Given this list of marker genes Lig3, Nuggc, Dach1, Mtnap1, Dynll1, Gmnc, Atrx, Endog, E2f7, Timeless (timeless circadian clock 1), Fbxo5, Zmpste24, Gmnn, Wiz, Ino80, Atg7, Mettl4, Cdc7, Cdk2, Aicda, Kat7, Ilkap, Ciz1, Ssbp1, Ager, Ticrr, Senp2, Tipin, Blm, Dbf4, Fgfr1, E2f8, Cdt1, Mcidas, Wrnip1, here is a description of the gene set: species: Mus musculus Mouse Gene Set: GOBP_REGULATION_OF_DNA_TEMPLATED_DNA_REPLICATION Any process that modulates the rate, frequency, or extent of DNA-templated DNA replication, the process in which new strands of DNA are synthesized.